Given this list of marker genes BRMS1L, NLK, GBP1, FIGN, ATAD2B, FAT1 (NCBI Gene Id 2195), THSD7A, SOCS6, CHUK, C2CD6, CENPW (centromere protein W), NDST3, ACVR1C, APBA2, ZBTB4, TMEM106B, CLGN, CNST, LIN54, SCYL2, RGS22, RCAN2, HDHD2, ZNF718, TBC1D8B, ANTXR2, FLVCR1, VDAC2, PPM1A, B4GALT6, EXOC5, SGIP1, MECP2, CFAP44, TBC1D20, SOS1, NTNG1, TOM1L1, SAR1B, CCDC39, IPMK, NOVA1, CHSY3, CLHC1, RCBTB1, FAM114A1, CREB5, RBM39, VEZT, CEP68, MRC1, ZCWPW2, CNIH3, ENTPD4, TWF1, WNK3, DMGDH, RFTN2, ZNF740, C14orf28, USP9X, CNTN1, ELMOD2, FZD3, ZSWIM6, TMEM47, SEMA3D, ZEB2 (zinc finger E-box binding homeobox 2, NCBI Gene Id 9839), KRAS, ARID2, DNAL1, FSD2, R3HDM4, C11orf58, EFNA5, CNOT6L, SERTAD2 (SERTA domain containing 2), SLC16A7, KCNJ6, IQCE, PCDHB12, MXD1, MTX3, AKR7A3, ALDH1A3, ARHGAP6, RNF11 (NCBI Gene Id 26994), TNFSF11, GHITM, MITF, RAB1A, PRKAA1, TENT5D, GNAS, CCDC73, HOXD3, LRP6, PI4K2B, HIF1A, E2F4, AGGF1, ZNF362, NAMPT, DCX, CARNMT1, BRD1, EFEMP1, ZNF451, PLET1, TRPC5, SAMTOR, PRRG4, GNG2, SLC30A6, RNGTT (NCBI Gene Id 8732), OSBPL8 (NCBI Gene Id 57601), PRKDC, ALKAL1 (NCBI Gene Id 389658), THSD4, FRMPD4, ZNF608, DYRK2, HLTF, LARP4, TRIM2, ZCCHC2, ARHGAP32, DAZL, ZBTB20, SYNCRIP, CAMSAP2, PIK3R1, PROX1, KPNA3, IL17A, PTAR1, PLEKHA5, SEC62, ZFP42, ANKRD12, KLHL29, DDO, RNLS, TAOK1, VCPIP1, PEX5L, CRPPA, PDE3A, BRWD3, NEK4, CLK4, IGF2BP2, CAMTA1, PHKB (NCBI Gene Id 5257), RALA, CD1D, AZIN1, ARL8B, ZBTB33, TMX3, DEFB134, GALR1 (galanin receptor 1), USO1, SERBP1, STK39, TBL1XR1, PTPN4, TBC1D4, CASP10, OTUD6B, RORA, TENM3, ASPH, CNOT1, PPFIA1, NHS, G6PC2, YTHDF1, ACVR1, REV3L, C8orf34, SAMD4B, PCGF5, C1QL3, TMF1, NUF2, BMX, SLC44A1, FUBP3, GDAP2, CHD1, OMD (osteomodulin), ATG3, CPNE8, APOLD1, ZNF492, HACD3, DGKE, XK, VIRMA, BAHD1, GLO1, RAD51AP1, DDHD2, MIGA1, TRDN, MOB1B, NFAT5, ZBTB39, FUNDC1, PMS1, SLC25A21, PCDHB7, NAA16, RPS6KA6, PLPP5, FBXO30, BCL11A, POLR1D, SMAD2, RB1, SLC19A2, SGK1, DDX42, HEATR6, ITGB8, TMCC1, RABGAP1L, PLS1, SESTD1, DENND4C, CYP4V2, TM9SF3, MAGEB4, SGPP1, DSC3, KDM6A, NUMB, KLHL42, USP31 (NCBI Gene Id 57478), TXLNB, CPEB2, GZMK, UTP14C, PSMC3IP, MINDY2, GPAM (NCBI Gene Id 57678), GK5, GGACT, GOSR2, HOMER1, RGS5, CRISPLD1, TTI2, CFHR5, MCIDAS, LATS1, ARFGEF3, BTBD3, EIF3A, EML4, LSM11, ABHD13, CDC14A, PHF8 (PHD finger protein 8), LZTFL1, ZNF322, CTBP1, IKZF5, FAM111A, LCMT2, NEGR1, PHC3, PHF6, HPRT1, LYSET, CCDC141, THUMPD1, FGF13, HSPA13, ATE1, LRRC58, CCDC186, ZEB1, ARK2C, KIAA0408, VNN1, NUP155, CENPK, SETD9, PYGO1, NUCKS1, NR4A2, PRKACB, NDFIP2, DISC1, TMEM135, LGSN, NR2C2, EBF3, ALCAM, CCDC148, IRS1, GRSF1, TSN, PGRMC1, PCDH17, SMAD9, TMEM74 (transmembrane protein 74), MMP1, SLC2A13, RGS13, MIS18BP1, ING3, VMP1, KCNK1, SPRY4, TBX18, HACE1, C5orf15, RASSF8, TAF5, FBXL18, WIF1, CLIP1, SMARCAD1, BTG1, LEPROT, GAB1, SMPD3, MTCL3, SF3B1, ZMYND11, SYNM, MYOCD, INSIG2, P2RY6, FAM20B, ZYG11B, TULP4 (TUB like protein 4), SDC2, PIAS1, VGLL3, ATP6AP2, PFDN4, ANGPT1, SKIL, GRM3, PDLIM5, SPAG1, SNX10, SFT2D3, ANKRD52, SKI, APPBP2, ZBTB10, NCEH1, TTBK2, POC1B, NIN, PTGIR, VAPA, TESMIN, TC2N, PJA2, SASS6, CUL5, DAZ2, AVL9, C11orf54, SEPTIN7, GLCE, UNC5D, CCDC91, DENND5B, TMED7, MAK16, TFAM, METTL9, ZNF550, ST8SIA3, TTPA, C21orf91, MAPK1, AP3B1, CAMK4, FAM76B, BOLA3, BMAL2, LPP, ADAM17, ZMYM2, KDM7A, TOMM70, HACD1 (NCBI Gene Id 9200), EPHA7, MYRIP, KIF20B, RHOA, RFX3, SPATA13, DR1, FAM200B, MEGF10, PDE10A, SLC30A7, here is a description of the gene set: from publication Chen Y, Wang X (PMID 31504780) Human Gene Set: MIR4799_5P Genes predicted to be targets of miRBase v22 microRNA hsa-miR-4799-5p in miRDB v6.0 with MirTarget v4 prediction scores > 80 (high confidence targets). studied in species Homo sapiens